The following is a description of a gene set: Human Gene Set: GOBP_NUCLEAR_MEMBRANE_REASSEMBLY The reformation of the nuclear membranes following their breakdown in the context of a normal process. species: Homo sapiens, and this is the list of marker genes: ANKLE2 (NCBI Gene Id 23141), UBXN2A, VPS4B, SPAST, SIRT2, CHMP2B (charged multivesicular body protein 2B), CHMP5, REEP4 (NCBI Gene Id 80780), CHMP2A, VPS4A, REEP3, CHMP3, BANF1, CHMP4B, CHMP4BP1, CHMP1B, CHMP4A, CHMP6 (charged multivesicular body protein 6), CHMP4C, RCC1, UBXN2B, NSFL1C, BROX, UBE2I, CHMP1A, CHMP7